Given this list of marker genes IL17RB (interleukin 17 receptor B), SOX4, IFI16, RBPMS, ALDH1A2, ANXA2 (annexin A2), MALL, PNRC1, HSPB1, LILRA2, ARMCX2, AMIGO2, TMEM176B (NCBI Gene Id 28959), SLC7A11, HOMER3, ACSL1, CYP1A1, PLAT, CD200, NTS, UCHL1, CREM, VCAN, P2RX4, NAP1L1, TCF7L2, NRCAM, EMP1, IL1RN, GDF15, KLF6, NQO1, MAGED2, ERG, CH25H, DDR1, ID1, ZNF217, GBP2, ECM1, QPRT, CRHBP, DUSP6, TM4SF1, here is a description of the gene set: Genes up-regulated by RUNX1-RUNX1T1 fusion protein in normal hematopoietic progenitors; their expression was sustained in subsequently developing erythroid lineage. The t(8;21)(q22;q22) occurs frequently in acute myelogenous leukaemia and gives rise to the transcription factor fusion protein, RUNX1-RUNX1T1 (also known as AML1-ETO). To identify the genes dysregulated by the aberrant transcriptional activity of RUNX1-RUNX1T1, we used microarrays to determine the effect of this mutation on gene expression in human progenitor cells and during subsequent development. Gene signatures of these developmental subsets were very dissimilar indicating that effects of RUNX1-RUNX1T1 are highly context dependent. We focused on gene changes associated with the granulocytic lineage and identified a clinically relevant subset of these by comparison with 235 leukaemia patient transcriptional signatures. We confirmed the overexpression of a number of significant genes (Sox4, IL-17BR, CD200 and gamma-catenin). Further, we show that overexpression of CD200 and gamma-catenin is also associated with the inv(16) abnormality which like RUNX1-RUNX1T1 disrupts core binding factor activity. We investigated the functional significance of CD200 and gamma-catenin overexpression in normal human progenitor cells. The effect of IL17 on growth was also assessed. Individually, none of these changes were sufficient to recapitulate the effects of RUNX1-RUNX1T1 on normal development. These data provide the most comprehensive and pertinent assessment of the effect of RUNX1-RUNX1T1 on gene expression and demonstrate the highly context-dependent effects of this fusion gene. Human Gene Set: TONKS_TARGETS_OF_RUNX1_RUNX1T1_FUSION_SUSTAINDED_IN_ERYTHROCYTE_UP from publication Tonks A, Pearn L, Musson M, Gilkes A, Mills KI, Burnett AK, Darley RL (PMID 17898786) species: Homo sapiens